The following is a description of a gene set: from publication Pujana MA, Han JD, Starita LM, Stevens KN, Tewari M, Ahn JS, Rennert G, Moreno V, Kirchhoff T, Gold B, Assmann V, Elshamy WM, Rual JF, Levine D, Rozek LS, Gelman RS, Gunsalus KC, Greenberg RA, Sobhian B, Bertin N, Venkatesan K, Ayivi-Guedehoussou N, Solé X, Hernández P, Lázaro C, Nathanson KL, Weber BL, Cusick ME, Hill DE, Offit K, Livingston DM, Gruber SB, Parvin JD, Vidal M (PMID 17922014) studied in species Homo sapiens Human Gene Set: PUJANA_BRCA2_PCC_NETWORK Genes constituting the BRCA2-PCC network of transcripts whose expression positively correlated (Pearson correlation coefficient, PCC >= 0.4) with that of BRCA2 across a compendium of normal tissues. Many cancer-associated genes remain to be identified to clarify the underlying molecular mechanisms of cancer susceptibility and progression. Better understanding is also required of how mutations in cancer genes affect their products in the context of complex cellular networks. Here we have used a network modeling strategy to identify genes potentially associated with higher risk of breast cancer. Starting with four known genes encoding tumor suppressors of breast cancer, we combined gene expression profiling with functional genomic and proteomic (or 'omic') data from various species to generate a network containing genes linked by 866 potential functional associations. This network shows higher connectivity than expected by chance, suggesting that its components function in biologically related pathways. One of the components of the network is HMMR, encoding a centrosome subunit, for which we demonstrate previously unknown functional associations with the breast cancer-associated gene BRCA1. Two case-control studies of incident breast cancer indicate that the HMMR locus is associated with higher risk of breast cancer in humans. Our network modeling strategy should be useful for the discovery of additional cancer-associated genes., and this is the list of marker genes: SMC4, SRP9, H2AX, HLTF, FOXM1 (forkhead box M1), CCNA2, DHFR, MCM7, ATN1, DUT, CD2AP, ILF3, DDX23, GINS1, RIF1, RFC5, CDKN2C, PPP1CC (NCBI Gene Id 5501), ZNF253, STAG2, ITGA4, CBX3, MED20, CCND3, CDC25B, ARHGAP19, LIG3, KIF22, ACAT2, LIG1 (NCBI Gene Id 3978), HPRT1, GLRA2, SNRNP200, PRKDC, ANP32E, RTCA, TMEM106C, PLK4, CENPC, BAX, FDFT1, ITM2A, CSNK2A1, WDR77, SYCP2, DHX15, SRSF11, SMARCA4, ZNF131, SKP2, FANCG, ZNF330, XRCC3, MCM5, BUB1B, NCAPH, STMN1, MYBL1, TUBGCP3, LSM4, HMMR, RAG1, MAP2K6, POMK, TROAP, UBE2C, ACYP1, NFATC2IP, MFHAS1 (multifunctional ROCO family signaling regulator 1), RRM2, CLINT1, RAD51C, ARHGEF7, CD1C, TTK, SUZ12, CD47, SEPHS1, SLC7A1, BCAS2, DDX39A, MAPRE1 (NCBI Gene Id 22919), SNRPA1, KIF2C, SPAG5, ADK, EIF3H, DBF4, AURKB, YTHDC2, DNTT, LINC00869, RRM1, ZNF273, BRCA2 (NCBI Gene Id 82716), RPP30, PEX1, FNBP4, ITGB3BP, ABCB7, NUDT21, KNTC1, CNTRL (centriolin), TMPO, CHRNA5, EZH2, HNRNPUL1, MUTYH, IL15, TOP2A, CDC23, DNA2, GFRA1, STIL, NASP, LAT, TCF3, DDX46, TFDP2, SRSF3, DDX39B, TRIM28, FAT1, CASP6, CHEK1, SLC25A46, SRPK1, CPSF4, CSTF1, CDC25C, ATAD2B, MYBL2, PRP4K, TMEM186, TIMELESS, TTF2, HCFC1, RAE1, HMGN4, MAZ, CBX1, RNASEH2A, AURKA, MAD2L1, FOXK2, ALDH1A2, MKI67, POLD2, TOP1, CDC6, MLH1, FADS1, DPY19L2, PHF20, CHI3L2, GNPAT, FANCI, CD1B, THAP9-AS1, FZD2, NDC80, TFDP1, POLE2, NFYB, WRN (WRN RecQ like helicase), NINL, GMPS, KIFC1 (kinesin family member C1), TOPBP1, BRCA1 (BRCA1 DNA repair associated), SRSF10, DESI2, NCK1, UBE2I (ubiquitin conjugating enzyme E2 I), RHOH, RBBP4, PAK2, INSIG1, ATP11B, TCERG1, TMSB15A, TRRAP, DDB2, HMGXB4, UBE2S, TBCD, TOX, PFDN4, PAICS, VAV1, CXCR4, TPX2, TCP1, PCLAF, DCP2 (NCBI Gene Id 167227), RUNX1, PTPN22, POLR2G, PRKCA, KIF14, SMC5, RBCK1, CNOT3, SH2D1A, RFC3, RAD21, DDX11, ORC2, GATA3, IDH3B, NR2C1, RNF4, CDC27, ESPL1, SAC3D1, FASTKD2, PRPS1, TBC1D31, DTYMK, ENSG00000291006, BARD1, CDC20, RPA1 (NCBI Gene Id 6117), DEK (NCBI Gene Id 7913), ZNF184, MRPL9, KIF23, RAD1, PRKCQ, PRPF4, TRAT1, PAQR3, DLGAP5, RFC4, CDK1, BLMH, TBCA, ABCC1, LCK, CASP2, IL10, CCNB2, TMEM131L, TYMS, DLEU2, PIKFYVE, MCM3, NFATC3, MSH2, CDT1, GTF2H2, KIF20B, SNRPA, METAP1, CD3D, CCR9, DNAJC9, ZNF85, CTPS1, ZNF101, TIAL1, ZAP70 (NCBI Gene Id 7535), FUBP1, HSF2, PAXIP1 (PAX interacting protein 1), COX11, SSBP2, CCNF, MDM2, NUP93, POLD3, E2F1, NELFA, GUSBP3, WDHD1, MELK, CTBP1, CD3E, PNN, PTDSS1 (phosphatidylserine synthase 1), VPS13A, COPS3, CD1A, NFYA, SPC25, ARHGDIB, TAF4, NUP205, SSRP1, KIF11, RCBTB2, CENPA, RALY, ADA, TRBC2, TAF1C, SNRPB, MRE11, CTCF, MTF2, ELOVL5, SMC3, CLGN, GTSE1, RAD51AP1, TTI1, GRAP2, DNMT1, LMNB1, CYB5B, CCNE2, CENPE, KCTD20, CKAP5, XRCC5, SMC2, HDAC4, XPO1, CENPF (NCBI Gene Id 51468), CDKN3 (NCBI Gene Id 1033), CNOT9, RAD54L, CAD, CAMK2B, SIVA1, TAF11, UNG, CD1E, PCCB, POLE, GNA15, PCNA, RPIA, DCBLD2, OGT, STAU2, LCOR, PPP2R5C, EXOSC2, NEMP1, TRIM24, H2AZ2, RCE1, MPHOSPH9, HDAC3, RECQL, KATNA1, LBR, STAT5A, CEP290, NSD2, NCAPD2, TTF1, ATR, PSIP1, FEN1, LCT, HMGN1, RBBP5, SMPD4, AGPS, FANCA, USP1, GLMN, MCM4, TCF7, ZWINT, SMC1A, EXOSC8, LEF1, CCNB1, LIG4, CHEK2, PRIM1, RAG2, CHAF1A, BUB1, HMGCS1, MACROH2A1, LARP7, MAT2A, ZNF84, CPSF6, RBBP8, UBR5, CEP57, EPHB6, MYB, ZNF354A, TRAPPC6A, TLK2, FRG1, CPSF1, ASXL1, MCM2 (minichromosome maintenance complex component 2), POLD1, MPHOSPH6, KIN, ZNHIT3, BUB3, POLA1, KIAA0930, ZBTB39, BLM, CDC7, ZNF43, RB1, HMGB2, AATF, DNAJC5, KDM1A, MCM6, SEPTIN6, PRR3, RFXAP, POLR2B, CENPX, CKS2, PTTG1, HIRIP3, RNASEH2B, ASF1A, CDC45, EXOSC9, NAE1, BTAF1